The following is a description of a gene set: studied in species Homo sapiens from publication Chen Y, Wang X (PMID 31504780) Genes predicted to be targets of miRBase v22 microRNA hsa-miR-3164 in miRDB v6.0 with MirTarget v4 prediction scores > 80 (high confidence targets). Human Gene Set: MIR3164, and this is the list of marker genes: OPALIN, NOC2L, ANGPTL3, ZNF648, EGR3, PARP12, RBMX, SLC49A4 (NCBI Gene Id 84925), ITGB8, ENOSF1, NYNRIN, RAB21, BCL9L, SOS1, STXBP1 (syntaxin binding protein 1), SLC2A4, SRRM4, MEIS2, CPSF6, PARPBP, COL5A2, PUM2, ZNF503, REP15, KRAS, ZC3H12B, KDM6A (NCBI Gene Id 7403), NUDT13, CYP2R1, BLTP1, ZNF559, ZKSCAN1, CACNG3 (calcium voltage-gated channel auxiliary subunit gamma 3), USP12, POLDIP2, MTCL1, HSFX3, KIF3A (NCBI Gene Id 11127), NPHS2, C4orf33, ABTB3, CTNNA1, GRIK2, HNRNPLL, ACSL4, CLPSL2, OSBP, MID1, COX15 (cytochrome c oxidase assembly homolog COX15), KLHL14, IL1RAP, PDE12, FAM120C, CPEB1, DST, RUNX1T1, EPN3, XKR6, AGL, TXNDC16, TMED7-TICAM2, DGKH, HDAC5, TICAM2, LINC02874, PADI4, C1orf116, ST6GAL2, TMEM50B, INPP5A (NCBI Gene Id 3632), TESMIN, IAH1, DGKE, ATP1B1, ZNF268, SH3TC2, CISD1, PRKAA1, MYO5B, SRD5A2, ABCB5, TMEM248, ASH1L, HSD17B13, HIRA, MARCHF1, ZNF879, MPDZ, GUF1, SCN1A, RNF103, ZNF28, SMIM9, P2RX2, ITGB1, RABEP1, INA, HS6ST2, OVOL1 (ovo like transcriptional repressor 1), MFAP3L, SLFN5, PEX11A, RDH10, MAP4K3, ATP8A1, ZNF25, SEPSECS, MTRR